Given this list of marker genes MAP2K6, DUSP1, MAPK14, NFKB1, SMAD4, IKBKG, MAP3K1, NFKBIA, VDR, CHUK, IL6, NR3C1, MAP2K3, NFATC1, RXRA, RELA, TNF, PPP3CA, PPP3R1, IKBKB, MED14, SMAD3, here is a description of the gene set: studied in species Homo sapiens Vitamin D in inflammatory diseases Human Gene Set: WP_VITAMIN_D_IN_INFLAMMATORY_DISEASES